The following is a description of a gene set: Mouse Gene Set: MIR_551B_5P species: Mus musculus Genes predicted to be targets of miRBase v22 microRNA mmu_miR_551b_5p in miRDB v6.0 with MirTarget v4 prediction scores > 80 (high confidence targets). from publication Chen Y, Wang X (PMID 31504780), and this is the list of marker genes: Stx16, Cecr2, Otud4, Atp11a, Pitpnc1, Pcdh7, Ercc6l2, Spred1, Tmod3, F13b, Cacybp, Elovl6, Irf2bp2, Elapor2, Atoh1, Ifi214, Gpr22, Bahd1 (bromo adjacent homology domain containing 1), Rufy3, Ep300, Slc31a1, Rsbn1l, Sesn1, Mia2, Birc6, Plxnd1 (plexin D1), Prl3a1, Rag1, Plscr2, Kdm7a, Rab11a, Fubp3, Otud7b, Ralbp1, Gm6377, Spint2, Hmgcs1, Mgat4b, Mbnl1, Kcnma1, Cadm2, Mosmo, Yipf4, Cdyl2, Ncoa7, Nsd3, Zc3h12c, Cnot6l, Rictor, Mark2, Sirpa, Ssh2, Tmem33, Yipf6, Rab18, Adnp2, Map3k20, Dbt, Cpne3, Lnx2, Pxylp1, 9330159F19Rik, Dcaf10, Gabrb2, Scai, Nr2e1 (NCBI Gene Id 21907), Sox4, Sec23a, Celf1, Cmtm6, Cdc40, Sem1, Stx12, Tafa4, Zfp518a (zinc finger protein 518A), Cpeb3, Jph1, Sox11, Acad8, Rap2c, Mllt3, Mctp2, Pcdh9, Srsf6, Dennd4c, Tulp4, Mycn, Pknox1, Ube2q2, Arpp19, Acnat1, Bmpr2 (NCBI Gene Id 98751), Rad17, Mex3c (NCBI Gene Id 399620), Noc3l, Mylk, Fmn1, Jag1, Snx10, Chd9, Rsf1, Tm2d1, Man1a2, Trappc10, Zfx, Pcnx3, Edem3, Ube2d3, Hic2, Ctsc, Rtraf, Sp4, Kctd18, Kif5b, Baz1a, Copa, Qki, Eny2, Rag2, Cipc, Fat1, Clpx, Cpe, Onecut2, Nalcn, Dpp10, Slc8a1, Rnd3, Tmx3, Rfx3, Ndufaf7, Tbc1d23, Enpep, Samd4, Nek4 (NCBI Gene Id 23955), Mdm4, Usp9x, Galnt2, Tat, Neurog2, Or4n5, Uchl5, Gvin1, Pgr15l, Spdye4a, Snx27 (sorting nexin family member 27), Cep97, Sult2a8, Zkscan1, Gabrg1, Nln, Sesn3, Tbpl2, Tmem183a, Alcam, Gpr45, Rnf138, Glce, Efhc2, Mndal, Atp8a1, Btbd7, Smarca5, Col25a1, Bod1l, Nova1, Gbp7, Smad2, Ccnd1, Fndc3b (fibronectin type III domain containing 3B), Fhip1a, Tra2a, Lrp6, Pfkfb2, Inpp5a, Pgap1 (post-GPI attachment to proteins 1), Rfx7, Csnk1g3, Slc7a14, Sugct, Bsn, Cab39, Senp1, Ireb2, Capza1, Kcnj3, Kbtbd7, Dnai4, Zfp148, Tmem64, Myo1d, Pfkp, Fnip1, Ssbp2, Ajap1, Acsl3, Ifi209, Trim59, Sptssa, Gpr75, Plac8, Kcna2, Ube2e2, B3galt1, Atad2b, Plcxd2, Parg, Cacul1, Itga4, Ap3m1, Mospd2, Phf3, Kdm5a, Cep350, Phlpp1, Idi1, Cpeb2, Armc8, Pcdh17, Mob3b, Txndc16, Kdsr, Dach1, Eeig2, Cul3, Larp4 (La ribonucleoprotein 4), P2ry13, Lpar6, Klhl28, Zbtb2 (zinc finger and BTB domain containing 2), Rrh, Cdc14a, Clint1, Slc30a4, Ccn4, Mier3 (MIER family member 3), Ube2d2a, Taf3, Tdrd3, Ninl, Cdkn2c, Gsr, Abca5, Taf5, Tox3, Azin1, Ncor1, Nsmce3, Sgo2a, Bend4, Prkaa1, Zbtb6, Cct2, Zfp638 (NCBI Gene Id 18139), Ifi44, Pwwp3b, Fgfr2, Sat1, Gvin2, Trpc5os, Ell2, Phc3, Usp37, Pou2f1, Spire1, H2bc21, Fam120a, Prok2, A4gnt, Matr3, Tbc1d15, Rbm3, Pabir2, Il7r, Spg7 (SPG7, paraplegin matrix AAA peptidase subunit), Hbp1, Erbin, Rere, Gjd2, Pik3r5, Gvin3, Cep57l1, Naaladl2, Galc, Aff4, Tshz1 (NCBI Gene Id 70498), Gipc2, Ube2g1, Btf3l4, Tmigd1, Rab2a, Map3k2, Lurap1l, Dkk1, Nup160, Gosr1, Pyurf, Gimap8, Scn1a, Gm5622 (predicted gene 5622), Cnnm4, Ppp1r9a, Strbp, Csnk1e, Arid1b, Limch1, Spty2d1, Uhrf2, Pabpc1 (poly(A) binding protein, cytoplasmic 1), Slc35f1, Arih2, Ythdf3, Pah, Ccnc, Glra2, Mdga2, Clock, Pex3, St8sia1, Caprin1, Trib2, Gpm6a, Ank1 (NCBI Gene Id 11733), 4930503E14Rik, Elf2, Alx1, Avpr1a, Acer3, Hepacam2, Fam169a, Negr1, Elavl1, Nbeal1, Nufip2, Eaf2, Mad2l1, Igf2r, Gm8267, Agpat5, Sp8, Kif3a, Pard6b, Casz1, Ptp4a2, Tent2 (terminal nucleotidyltransferase 2), Fcho2, Wasf1, D630045J12Rik, Gfpt1, Slc4a7, Zfp711, Galnt7